Given this list of marker genes Kat2b, Maml1, Dtx1, Ubb, Jag2, Ep300, Itch, Mamld1, Uba52rt, Maml3, Maml2, Notch1, Uba52 (NCBI Gene Id 56512), Kat2a, Dtx4, Ubc, Dtx2, Rbpj, Rps27a, here is a description of the gene set: Mouse Gene Set: REACTOME_SIGNALING_BY_NOTCH1 Signaling by NOTCH1 species: Mus musculus